The following is a description of a gene set: studied in species Homo sapiens The process in which the anatomical structures of the ureter are generated and organized. The ureter is a muscular tube that transports urine from the kidney to the urinary bladder. Human Gene Set: GOBP_URETER_MORPHOGENESIS, and this is the list of marker genes: GATA3, SOX8, SOX9, LHX1, BMP4, LZTS2, EMX2